Given this list of marker genes CCNC, SULF1, SORBS1, RRAGD, ZNF827, BASP1, PELI2, UBLCP1, HTR2C, C17orf75, LAMTOR3, ALG14, NIPBL (NIPBL cohesin loading factor), CNOT6, PABIR1, SALL1, ARID4A, RAB9B, PRDM6 (PR/SET domain 6), CRK, DISC1, PLLP, TTC7B, SOX6, DAZ4, IGF1R, PIK3C2A, CBR4, METTL8, COL25A1, KPNA6, DAZ2, C11orf58, ADIPOR2, STEAP2, MMD, EXOSC1, GPATCH2L, TFAP2D, GPM6B, GNG4, TBC1D12, NAMPT, ILF3, STING1, FLI1, PCNX1 (NCBI Gene Id 23690), LY75, MBNL1, HEG1, DAZL, ANXA6, PPP3R1, FAM227B, NAP1L1, OSTC, RNF121, ATXN2, PTGES2, CEBPZ, KATNAL1 (katanin catalytic subunit A1 like 1), ANTXR2, SYT1, BMAL2 (NCBI Gene Id 56938), GARS1, DAZ3, CUL4B, DGKG, STXBP1, MZT1, EEF1A1, NPR3, PPP4R2, TBC1D5, NRAS, DAZ1, PPP1R10, KDM7A, GRIA1, SLC11A2, ZBTB41, SLX4IP, RNF135, C4orf36, FCHO2, NETO2, SEL1L, QSOX2, PHIP, RNF32, BDP1, C2orf69, ZFX, ARID2, BLOC1S5, PDE4DIP, ZPBP (NCBI Gene Id 91091), WIPI2, NRP1, KLHL3, FBXO48, CAMTA1 (NCBI Gene Id 23261), KLHL15, KRAS, WDR38, ZNF695, PLAC8L1 (PLAC8 like 1), PGAM1, MAPK8, SCLY, SLC9A5, ZBTB20, ACVR2B, MANBA, OGFOD1, here is a description of the gene set: studied in species Homo sapiens from publication Chen Y, Wang X (PMID 31504780) Human Gene Set: MIR181A_2_3P Genes predicted to be targets of miRBase v22 microRNA hsa-miR-181a-2-3p in miRDB v6.0 with MirTarget v4 prediction scores > 80 (high confidence targets).